Given this list of marker genes Slc9b2, Nptx1, Sap18, Nrsn1, Mapk8, Hs1bp3, Cotl1, Wdr48, Gadd45b, Polg2, Pdcd7, S100a6, Apc, Rragd, Socs2, Acsm3, Serpini1, Tram1, Dnaja1, Dok2, Wdr45b, Cd1d2, Rag2, Wdtc1, Cyth1, Cep89, Atp2a3, Pttg1, Mcm3, S100a4, Rasgrp2 (RAS, guanyl releasing protein 2), Tuba1a, 1810037I17Rik, Cd1d1, here is a description of the gene set: Genes down-regulated in LSK cells (bone marrow) as a function of a QTL for the size of hematopoietic stem cell (HSC) population: comparison of congenic D.B. Chr 3 (DB, small HSC population) vs parental D2 strain (huge HSC population). from publication Liang Y, Jansen M, Aronow B, Geiger H, Van Zant G (PMID 17220891) Mouse Gene Set: LIANG_HEMATOPOIESIS_STEM_CELL_NUMBER_SMALL_VS_HUGE_DN studied in species Mus musculus We mapped quantitative trait loci that accounted for the variation in hematopoietic stem cell (HSC) numbers between young adult C57BL/6 (B6) and DBA/2 (D2) mice. In reciprocal chromosome 3 congenic mice, introgressed D2 alleles increased HSC numbers owing to enhanced proliferation and self-renewal and reduced apoptosis, whereas B6 alleles had the opposite effects. Using oligonucleotide arrays, real-time PCR and protein blots, we identified latexin (Lxn), a gene whose differential transcription and expression was associated with the allelic differences. Expression was inversely correlated with the number of HSCs; therefore, ectopic expression of Lxn using a retroviral vector decreased stem cell population size. We identified clusters of SNPs upstream of the Lxn transcriptional start site, at least two of which are associated with potential binding sites for transcription factors regulating stem cells. Thus, promoter polymorphisms between the B6 and D2 alleles may affect Lxn gene expression and consequently influence the population size of hematopoietic stem cells.